Given this list of marker genes Rara, Tyk2, Traf2, Crlf2, Cd6, Ddx1, Chuk, Tnfsf18, Selenok, Rel, Cd40, Cyrib, Il16, Ins1, Spon2, Mapkapk2, Gpsm3, Nfatc4 (NCBI Gene Id 73181), Il15 (interleukin 15), Il2, Crhr2, Ighd, Il1a, Cd200, Ifih1, Hif1a, Zfp580, Adra2a, Nlrc4, Nr1h4, Itk (NCBI Gene Id 16428), Hk1, Tank, Gata4, Lgals9, Rsad2, Pde4b, Batf, Tlr6, Oas1g, P2ry2, Il1rl1, Abl2, Ccr2, Ereg, Zfpm1, Spn, Epx, Cx3cl1, Cd55b, Agt, Lamtor5, Riok3, Hc (hemolytic complement), S100a13, Gimap3, Pycard (PYD and CARD domain containing), Nmbr, Chil6, Camp, Kpna2, Csf1r, Sulf2, Tnfrsf13c, Cd300c2, Hdac2, Cd27, Ifi209, Gapdh-ps15, Ifnb1, Pibf1, Sema7a (NCBI Gene Id 78407), Alox8, Dhx58, Fcna, Ltb, Ifi214, Ccl2, Ripk2, Pnp2, Polr3b, Ccbe1, Sorl1, Malt1, Prg3, Trim6, Pla2r1, Ly96, Traf3, Jak2, Cd274, Cebpb, Atp6ap2, B2m, Panx1, Tmem106a, Vtcn1, Arhgef2, Mbp, App, Psen1, Il1b, Il17a, Rora, Clec4e, Ptprj, Afap1l2, Isl1, Ephb2, Oas1e, Klre1, Gsdma3, Crtam, Il4, Fgr, Zc3hav1, Cd209b, Hspa1b, Arnt, Mavs, C5ar1, Atf2, Arid5a, Tomm70a, Mif, Clec5a, H2-T23, Cd36, Casp1, Htr2a (NCBI Gene Id 239184), Lrrfip2, Rasgrp1, Irf3 (NCBI Gene Id 54131), Cd160, Hmgb1, Ins2, Klrk1, Il27ra, Il9, Rab2b, Chil5, Oas1d, Mcoln2, Il6ra, Tgfb1, Btnl2, Ffar2, Hilpda, Hyal2, Peli1, Il33 (interleukin 33), Phb1, Ccr5, Cd74, Trem2, Arrdc4, Aim2, Tek, Park7, Il17b, Serpinb7, Casp8, Lilra5 (NCBI Gene Id 232801), Rnf135, Foxp1, Polr3g, Rock2, Sirt1, Wnt11, Ccl19, Cybb, Sphk1 (NCBI Gene Id 66122), Mmp8, Csf2, Ccl3, Agtr2, Fcgr3, Il17d, Panx2, Il23r, Cd1d1, Appl1 (adaptor protein, phosphotyrosine interaction, PH domain and leucine zipper containing 1), Atf4, Clec7a, Foxp3, Hpse, Stat5b, Ifi213, Ankrd42 (NCBI Gene Id 73845), Xbp1, Oas3, Nlrp3, Elane, Oas1a, Wnt3a, Cd84, Runx1, Ticam2, Lrrk2, Il12rb2, Gdf2, Myb, Casp4, Akirin2, Lep, Myd88, Prg2 (proteoglycan 2, bone marrow), Cd55, Heg1, Il36g, Lrp1, Cd34, Card11, Ikbke, Ccm2l, Wnt5a, Panx3, Cd1d2, Fcgr1 (NCBI Gene Id 99852), Stat1, Hgf, Dhx33, Irak1, Kit, Ulbp1, Polr3a, Lbp, Ccdc88b, Il20rb, Ticam1, Inava, Irf5, Vegfd, Src, Kpna6, Nod1, Nlrp10, Il17rb (interleukin 17 receptor B), Grk2, Raet1d, Il4ra, Pde4d, Rad21, Prkcz, Cd83, Zbtb20, Il36a, Tarm1, Cd276, Icosl, Nlrp9b, Clec12a, Hmgb2, Pou2af1, Tut4, Serpine1, Trpv4, Clec9a, Clu, Sphk2, Aif1, Unc93b1, Il27, Opa1, Lurap1, Adora2b, Il23a (NCBI Gene Id 83430), Laptm5, Txk, Xiap, Tmed10, C1qtnf3, Ptgs2, Fcnb, Dennd1b, Nras, Smad3, Oas2, Rbm47, Cd28, Garin5a, Gapdhrt2, Fcer1g, Ly9, Pou2f2, C3, Ifng, Klrh1, Kat2a, Tbk1, Il1rap, Serpinf2, Cd2, Pten (phosphatase and tensin homolog), Ptpn22, Kpna2rt, Scimp, Il1r1 (NCBI Gene Id 16177), Il21, Stat5a, Creb1, Usp50, Trim27, Il36b, Nod2, Isg15, Abcc8, Hspb1, Polr3c, Optn, Nfam1, Btk, H2-Q7, Il17c, Tlr5, Ffar3, Zcchc3, Egr1, Tnfrsf14, Traf3ip3, F2rl1, Stoml2 (NCBI Gene Id 66592), Agpat1, Trim56, Scrib, Lum, Clnk, Lta (lymphotoxin A), Ifi203-ps, Il17rc, Mir324, Il10, Cd3e, Slc7a5, Tlr1, Hspd1, Prkd2, Irf7, Mapk11, D1Pas1, Syk, Oas1c, G3bp1, Fadd (NCBI Gene Id 14082), Adipoq, Mmp12, Tnfrsf8, F3, Havcr2, Bmpr1a, Tirap (NCBI Gene Id 117149), Nos2, Ddx3x, Chia1, Tlr8, Slamf1, Postn, Il1rl2, Rtn4, Pqbp1, Tigit, Glmn, Adam8, Tnfrsf1a, Scamp5, Fermt1 (NCBI Gene Id 241639), Plcb1, Fcer1a (NCBI Gene Id 14125, Fc receptor, IgE, high affinity I, alpha polypeptide), Gsdmd, Ddx21, Bsg, Agpat2, Cd81, Sting1, Ifnar1, C3ar1, Ifngr1, Flot1, Cadm1 (cell adhesion molecule 1), Sptbn1, Tbc1d23 (NCBI Gene Id 98049), Irf8, Hsp90aa1, Cyp1b1, Brca1, Trim32, Adcyap1, Ptger4, Il12b, Il12rb1 (NCBI Gene Id 270057), Ptpn11 (NCBI Gene Id 72646), Ifi207, Mapk13, Pnp, P2rx7, Il7, Mdk, Cxcl17, Dhx9, Zp3, Tradd, C1qtnf4, Ddit3, Pla2g3, Fcgr2b, Mefv, Cgas, Trim65, Map3k7, Flt3, Cebpg, Agtr1a, Pik3r1, Gbp4, Nodal, Irf1 (NCBI Gene Id 16362), Ptafr (NCBI Gene Id 636551), Tmf1, Sod1, Mndal, Tyrobp, Cd209d, Dhx36, Tnf, Gapdhrt, Setd4, Il13, Ido1, Anxa1, Rab7b, Rab1a (NCBI Gene Id 19324), Prkca, Usp22, Ripk1, Tnfsf9, Ccl5, Adam17, Tlr2, Prkcq, Irak3, Mapk14, Twist1, Dlk1, Ncl, Cyp2j6, Rgcc, Chi3l1, Psg22, Polr3f, Trim15, Setd2, Oas1f, Stmp1, Aire, Naip5, Apoa2, Slc11a1, Polr3d, Cd40lg, Mir155, Irf4, Flt4, Chil4, Cd244a, Hras, Lpl (lipoprotein lipase), Nlrp1b, Sash3 (SAM and SH3 domain containing 3), Osm, Tlr4, Tlr3, Ptprc, F2r, Ifi208, Oas1h (NCBI Gene Id 246729), Mir21a, Il18, Plcg2, Nlrp1a, Tbx21, Tlr9, Cd46, Card9, Htr2b, Tslp, Slamf6, Ccl20, Il17ra, Chil3, Frmd8, Tusc2, Gata3, Gapdh (glyceraldehyde-3-phosphate dehydrogenase), Uap1, Fzd5, Ccl4, Ifi203, Rigi, Il18r1, Nr4a3, Gprc5b, Gbp5, Il12a (NCBI Gene Id 16159), Eif2ak3, Traf6, Akap12, Rps3, Sulf1, Ager, Nox1, Tmed10-ps, Tnfsf4, Ucn (NCBI Gene Id 22226), Arfgef2, Nmb, H2-M3, Rftn1, Lacc1, Oas1b, Thbs1, Ifi206, Xcl1, Rela, Drd2, Cd226, Stat3, Il6, Gimap5, Ccr7, Tnfsf15, Ccl1, Ceacam20, Zbtb7b, Bcl3 (NCBI Gene Id 12051), Il17f, Defb25, Mapk9, Cd14, Cyba, Clec4n, Eif2ak2, Tlr7, Carmil2, Bcl10, Abl1, Ccn1, here is a description of the gene set: species: Mus musculus Any process that activates or increases the frequency, rate or extent of production of a cytokine. Mouse Gene Set: GOBP_POSITIVE_REGULATION_OF_CYTOKINE_PRODUCTION